Given this list of marker genes NDC80, TTK, AURKA, MLH3, TRIM75, TUBB8, WASHC5, CDC25B, MEIKIN, SYCP2, MASTL, TRIP13, SKA1, HSF1, SPIRE1, PLK1, PTEN, NCAPH, EREG, ORC4, TOP2A, MLH1, RBM46, SPIRE2, PPP2R1A, FMN2, NCAPH2, FBXO5, MARF1, SKA2, DAZL, ATM, SKA3, MEIOB, WEE2, HSF2BP, DCAF13, UBB, MEIOC, SEPTIN1, DDB1, BRME1, CCNB2, here is a description of the gene set: A cell cycle process by which the cell nucleus divides as part of a meiotic cell cycle in the female germline. Human Gene Set: GOBP_FEMALE_MEIOTIC_NUCLEAR_DIVISION studied in species Homo sapiens